Given this list of marker genes CDH7, DAZ1, MED27, CNOT4, GIPC3, CPD, MAGEE2, SEC22B, MBNL3, INA, POSTN, MYT1 (NCBI Gene Id 4661), LYSMD2, RTF1, NAA16 (N-alpha-acetyltransferase 16, NatA auxiliary subunit), PCDH7, ZNF22, RTKN2, DAZ4 (deleted in azoospermia 4), WEE1 (NCBI Gene Id 7465), CARHSP1, ATP5PB, UFM1, GID4, DAZ3, RPS3, ATP1B4, TRAK1 (NCBI Gene Id 22906), DAZ2, HERC3, NPY2R, RBL2, DOK6, ADAM7, ZNF90, SLC18A2, ANKRD18A, KCNK1 (NCBI Gene Id 3775), CYB5R4, USP46, ABL1, DAZL, HOMER1, ARID1A, ELOVL6, PXYLP1, CPXCR1, LARP1B, SLC35C1, ZC3H6, ZNF135, ESR1, DDX43, FIGNL2, FCHSD2, SOD1, LRP6, SUGP2, here is a description of the gene set: Genes predicted to be targets of miRBase v22 microRNA hsa-miR-4320 in miRDB v6.0 with MirTarget v4 prediction scores > 80 (high confidence targets). from publication Chen Y, Wang X (PMID 31504780) studied in species Homo sapiens Human Gene Set: MIR4320